Given this list of marker genes TGM5, EPB42, TGM1, TGM6, TGM2, TGM3, F13A1, TGM4, TGM7, here is a description of the gene set: Human Gene Set: GOMF_PROTEIN_GLUTAMINE_GAMMA_GLUTAMYLTRANSFERASE_ACTIVITY studied in species Homo sapiens Catalysis of the reaction: L-glutaminyl- + L-lysyl- =-L-lysyl-N(6)-5-L-glutamyl- + NH4+. This reaction is the formation of the N6-(L-isoglutamyl)-L-lysine isopeptide, resulting in cross-linking polypeptide chains; the gamma-carboxamide groups of peptidyl-glutamine residues act as acyl donors, and the 6-amino-groups of peptidyl-lysine residues act as acceptors, to give intra- and intermolecular N6-(5-glutamyl)lysine cross-links.